Given this list of marker genes ASGR1, ENPP2, EGFEM1P, STAB2, ILDR1, MIA2, ITGAM, MRC1, ACKR2, STBD1, ABCA7, FPR2, LRP1, SCARB1, MEGF10, SCARA3, MARCO, COLEC12 (collectin subfamily member 12), DAB2, AGER, SDC1 (NCBI Gene Id 6382), SCARF1, SSC5D, CD163, LRP1B, LYVE1, ACKR3, DMBT1, LRP12, STAB1, MIA3, APOBR, LDLR, CUBN, HMMR, ENDOU, LRP2, LRP8, AMN, SURF4, MSR1, TEX261, OLR1, LGALS3BP, ITGB2, SCARF2, CD36, ASGR2, FOLR1, SORL1, VLDLR, SCARB2, VTN, LRP10, SCARA5, INSR, TFRC, FOLR2, ENPP1, LRP6 (LDL receptor related protein 6), ACKR4, ABCA1, CD320, TFR2, CXCL16, PRG4, here is a description of the gene set: Human Gene Set: GOMF_CARGO_RECEPTOR_ACTIVITY Binding specifically to a substance (cargo) to deliver it to a transport vesicle. Cargo receptors span membranes (for instance the plasma membrane or the endoplasmic reticulum membrane), binding simultaneously to cargo molecules and coat adaptors, to efficiently recruit the cargo molecules to nascent vesicles. studied in species Homo sapiens